Given this list of marker genes HNRNPU, SRSF2 (NCBI Gene Id 6427), PRPS1, ANP32B, PTBP1, DNAJC9, TRA2B, HMGB1, SRI (NCBI Gene Id 6717), VBP1, HMGN2 (NCBI Gene Id 94860), SUMO2, COPS3, HAT1, HNRNPAB, HMGB2, SMC4, SRSF3, GAR1, GTPBP1, SUZ12, SRSF1, SERBP1, USP1, MCM5, NUP153, PTGES3, HTRA2, DUT, HNRNPA3P1, NUDT1, ANP32E, CEP57, CBX3, DEK, EXOSC8, VRK1, here is a description of the gene set: studied in species Homo sapiens Human Gene Set: GNF2_ANP32B Neighborhood of ANP32B acidic (leucine-rich) nuclear phosphoprotein 32 family, member B in the GNF2 expression compendium Neighborhood of ANP32B